The following is a description of a gene set: Human Gene Set: HP_SENSORY_NEUROPATHY Sensory neuropathy studied in species Homo sapiens Peripheral neuropathy affecting the sensory nerves., and this is the list of marker genes: PRICKLE1, SPG11, DNMT1, NEFH, CLCN6, ENSG00000288330, ATXN8OS, GJB1, FXN, MT-ND5, POLG, PEX6, PPOX, MFN2, PLEKHG4, PRPS1, CTLA4, MT-TQ, TOP3A, XRCC4, LMNA, HEXB, CTSD, CRAT, SPTLC1, TFG, SPTLC2, ZFHX3, DNASE1L3, PI4K2A (phosphatidylinositol 4-kinase type 2 alpha), GSN, DHX16 (NCBI Gene Id 8449), MT-TL1, PEX1, AMACR, COMP, PLD3, ARL6IP1, CTDP1, TWNK, TGFB1, COX20, DST, PLP1, HNRNPA2B1, PTRHD1, HADHB, VRK1, TIMM8A, OPA1, HADHA, FGF14, PIEZO2, ATL1, NF2, LYST, REPS1, RAI1, NAGA, CAPN1, GAN, GJC2, ALS2, VCP, MT-TF, MT-TW, PRTN3, PNPT1, TDP1, TTPA (alpha tocopherol transfer protein), IBA57, PTPN22, MT-CO2, SLC12A6, HNRNPA1, AIFM1, TRPV4, SHMT2, MT-ATP6, MT-ND1, MORC2, ATP13A2, CCT5, VPS13A, ERLIN2, CACNA1A, MT-TS2 (mitochondrially encoded tRNA-Ser (AGU/C) 2), RAB7A, DHH, ATL3 (atlastin GTPase 3), HLA-DPA1, SAMD9L, DGUOK, TK2, TNXB, MT-TH, KLC2, HINT1, HLA-DPB1, RNU7-1, HK1, MT-CO3, SYNE1, NEUROG1, DMD, AR, ACOX1, ALAD, GNPTAB, RNF170, MT-CO1 (mitochondrially encoded cytochrome c oxidase I), MT-ND6, IARS2, DKK1, MT-ND4